Given this list of marker genes Ndst2, Or51e2, G6pdx, Agtr1b, Tacr1, F2rl1, Mcpt4, Cyp2j5, Rps6ka2, F2r, Prep, Prcp, Serpinf2, Nox1, Kcnn4, Ren1, Gja5, Drd3, Enpep, Ace, Mrgprd, Cyba, Comt, Ace2, Agtr1a, Ace3, Agtr2, Mme, Sucnr1, Anpep, Ednrb, Cyp11b2, Cpa3, Nkx2-1, Atp6ap2, Agt, Klk1b26, Mas1, Rhoa, here is a description of the gene set: studied in species Mus musculus The process in which renin-angiotensin modulates the force with which blood passes through the circulatory system. Mouse Gene Set: GOBP_REGULATION_OF_SYSTEMIC_ARTERIAL_BLOOD_PRESSURE_BY_RENIN_ANGIOTENSIN